Given this list of marker genes Gm14335, Pparg, Irak2, Creld1, Rho, Tatdn2, Gm43868, Tada3, Tmem40, Ogg1, Gm17733, Lmcd1, Mkrn2os, Rad18, Vgll4, Ssu2, Rpusd3, Tamm41, Gm24008, H1f8, Setd5, Grm7, Gm19040, Mir7660, Washc2, Emc3, Hrh1, Mbd4, Rassf4, Gm8132, Gm18485, Vhl, Cpne9, Raf1, Cand2, Gm23244, Gm5578, Cidec, Gm15519, Atp2b2, Tsen2, Ttll3, Gm6134, Mir7042, 9530062K07Rik, Srgap3, Cav3, Or6d14, Rpl32, Thumpd3 (THUMP domain containing 3), Gm15083, Sec13, Oxtr, Efcab12, Gt(ROSA)26Sor, Gm8213, Gm20404, Mkrn2, Slc6a11, Depp1, Mtmr14, Ghrl, Gm8083, Slc6a1, Gm18325, Tmem72, Alox5, Gm8203, Prrt3 (proline-rich transmembrane protein 3), Marchf8, Gm44180, Zfand4, D830050J10Rik, Lhfpl4, Atg7, Zfp422, Or6d15, 5031434C07Rik, Gm44336, Fancd2, Plxnd1, Snora7a, 1700015O11Rik, Gm22591, Il17rc, Or13a1, 1700054K19Rik, Ift122 (intraflagellar transport 122), Brpf1, Or6d13, Eif4a3l2, Gm20387, Gm20589, Mir7043, Tmcc1, Arpc4, Gm19039, Brk1, Or6d12, Timp4, Syn2, Il17re, Camk1, Gm22882, Gm36355, Jagn1, Fancd2os, Gm23527, here is a description of the gene set: Mouse Gene Set: chr6E3 studied in species Mus musculus